The following is a description of a gene set: Human Gene Set: GNF2_MKI67 species: Homo sapiens Neighborhood of MKI67 Neighborhood of MKI67 antigen identified by monoclonal antibody Ki-67 in the GNF2 expression compendium, and this is the list of marker genes: CDC20, NCAPG, CENPA, KIF20A, KIF11, CENPF, TOP2A, MELK, FOXM1, HMMR, KIF18B, CENPE, RRM1, RRM2, UBE2C, ESPL1, ASPM, NCAPD2, ZWINT, MKI67, MT1JP, CCNA2, NUSAP1, AURKA, TPX2, PCNA, CDK1, BIRC5